Given this list of marker genes Gata2, Ffar4, Trpv4, Fndc5, Napepld (NCBI Gene Id 242864), Vstm2a, Six1, Rreb1, Cebpa, Lncbate1, Flcn, Sox13, Mapk14, Lncbate10, Zfp423, Lamb3, Bnip3, Selenbp1, Pex11a, Adig, Adrb2, Hnrnpu, Metrnl, Bmp7, Slc7a10, Fabp4, Adrb1, Fbn1, Pim1, Mb, Slc2a4, Nudt7, Rgs2, Ebf2, Pparg, Dusp10, Cebpb, Scd1, Tfe3, Dhrs7b, Mecom, Mtor, Adipoq, Dio2, Sirt1, Lama4, Zbtb7b, Rarres2, Arl4a, Plac8, Ptgs2, Lrg1, Adrb3, Itga6, Zfp516, Ero1a, Mrap, Ucp1, Fto, Aldh6a1, Prdm16, Fabp3, Slc39a13, Lep, Sh2b2, here is a description of the gene set: The process in which a relatively unspecialized cell acquires specialized features of a brown adipocyte, an animal connective tissue cell involved in adaptive thermogenesis. Brown adipocytes contain multiple small droplets of triglycerides and a high number of mitochondria. Mouse Gene Set: GOBP_BROWN_FAT_CELL_DIFFERENTIATION studied in species Mus musculus